Given this list of marker genes CCN3, CD248, HTRA3, FNDC1, COL14A1, PROCR, IGFBP5, ALDH1A3, TNXB, TMEM100, SCARA5, TPPP3, CD55, EMILIN2, CADM3, EMP3, PCOLCE2, ANXA3, IGFBP6, GAS7, PLA1A, CLEC3B, EFHD1, MARCKS, PPP1R14B, FLNB, BASP1, PRSS23, THBD, PI16, FBN1, CREB5 (cAMP responsive element binding protein 5), ADAMTSL4, DBN1, PTGS1, SEMA3C, CMAHP, ACKR3, LURAP1L, LIMCH1, METRNL, ADAMTS5, CRIP1, PCSK6, MFAP5, AIF1L, SBSN, UAP1, here is a description of the gene set: In this study, an extensive analysis was conducted to define meta-programs (MPs) capturing intra-tumor heterogeneity across a spectrum of tumor types. The approach utilized non-negative matrix factorization (NMF) to analyze each cell type separately within individual tumor samples. This involved the analysis of malignant cells, macrophages, fibroblasts, endothelial cells, epithelial cells, T-cells, and B-cells. NMF was executed with varying parameter values (K=4, 5, 6, 7, 8, 9), thereby generating 39 programs for each cell type per sample. Each NMF program was summarized by the top genes based on NMF coefficients.\nRobust MPs were then delineated for each cell type using a set of stringent criteria, including recurrence within the same tumor, similarity to programs in other tumors, and non-redundancy within a tumor. Subsequently, these robust NMF programs were clustered (per cell type) based on Jaccard similarity, leading to the identification of MPs associated with each cell type.\nTo enhance the quality of the MPs, a refinement steps were undertaken, involving the removal of MPs suspected of reflecting low-quality data (with an overrepresentation of ribosomal proteins or mitochondrial-encoded genes), single-study inclusion, or similarity to miss-annotated cell types. species: Homo sapiens Human Gene Set: GAVISH_3CA_METAPROGRAM_FIBROBLASTS_PI16_POS Genes upregulated in subsets of cells of a given type within various tumors from publication Gavish A, Tyler M, Greenwald AC, Hoefflin R, Simkin D, Tschernichovsky R, Galili Darnell N, Somech E, Barbolin C, Antman T, Kovarsky D, Barrett T, Gonzalez Castro LN, Halder D, Chanoch-Myers R, Laffy J, Mints M, Wider A, Tal R, Spitzer A, Hara T, Raitses-Gurevich M, Stossel C, Golan T, Tirosh A, Suvà ML, Puram SV, Tirosh I (PMID 37258682)